Given this list of marker genes Stc1, Spint2, Scrib (NCBI Gene Id 54559), Hrh2, Col18a1, Pecam1, Fat1, Cdh5, Map3k1, Flnb, Tnmd, Cnmd, Plod3, Bcl11b, Magi1, Rab25, Ihh, Rock1, Ccdc88c, Palld, Rnase10, Dact2, Id1, Heg1, Frmd6, Cdh1, Arhgef26, Sipa1l3, Amotl2, St14, Jmjd1c, Cgn, Mir205, Notch4, Pkhd1, Grhl2, Adam7, Rilpl1, Clic4, Epb41l5, Rilpl2, Cldn3, Pard3, Pof1b (NCBI Gene Id 69693), Met, Hoxa13, Rac1, Ar, Vsig1, Luzp1, Ift88, here is a description of the gene set: species: Mus musculus The change in form that occurs when an epithelial cell progresses from its initial formation to its mature state. Mouse Gene Set: GOBP_EPITHELIAL_CELL_MORPHOGENESIS